Given this list of marker genes ZP4, CCR7, ACOD1, TNF, HPX, PTPRC, KLK3, KLK5, MIR520E, IL17F, PHB1, ZP3, PGC, TREM2 (triggering receptor expressed on myeloid cells 2), IL1B, IL17A, CR1, C3, FCGR2B, FCER2, KLK7, MIR520B, LTA, here is a description of the gene set: Any process that activates or increases the frequency, rate, or extent of a humoral immune response. Human Gene Set: GOBP_POSITIVE_REGULATION_OF_HUMORAL_IMMUNE_RESPONSE studied in species Homo sapiens